The following is a description of a gene set: Human Gene Set: GSE26030_TH1_VS_TH17_RESTIMULATED_DAY15_POST_POLARIZATION_DN Serial comparison between Th1 and Th17 tumor-specific cells cultured in vitro and ex vivo after transferred into sublethaly irradiated B6.PL mice. Th17-derived cells acquire Th1-like properties in vivo but maintain a distinct molecular profile. studied in species Homo sapiens from publication Muranski P, Borman ZA, Kerkar SP, Klebanoff CA, Ji Y, Sanchez-Perez L, Sukumar M, Reger RN, Yu Z, Kern SJ, Roychoudhuri R, Ferreyra GA, Shen W, Durum SK, Feigenbaum L, Palmer DC, Antony PA, Chan CC, Laurence A, Danner RL, Gattinoni L, Restifo NP (PMID 22177921) Genes down-regulated in T helper cells 15 days post polarization and stimulated with anti-CD3 and anti-CD28: Th1 versus Th17., and this is the list of marker genes: ITGB1 (integrin subunit beta 1), DUSP7, RBM6, SAMD1, CD68, SSR4, MAP7D1, NDUFA7, TRNAU1AP, POLR2E, PIN4, SF3B3, GLIPR1, RNF130, DNAJC17, LYL1, TEX261, FCER1G, GNB2, PSMD9, COPE, SPI1, LIN37, NAA10, KCNE3, MTARC2, ATP6V1F, TCF25, SLC25A17, SPR, PDYN, SARS1, EIF4A3, STAT3, ACP6, VAMP8, RABAC1, CLK3, SRRM4, TUSC2, DCTN5, NKX2-3, CORO1A, ZNG1B, NSA2, NACC1, SIGMAR1, RPL19, SEC31A, PPP6R1, IDH2, TUBB4B, CCNL1, RNF5, PSMB7, NDUFA10, PMM1, COX8A (NCBI Gene Id 1351), USE1, ALAS2, STUB1, TSPAN33, PFDN5, FXYD5, FAU, CASP8, ACIN1, HROB, COPG1, VPS28, SLC11A1, AAMP, EDEM2, BTLA, ZMAT5, CTSA, EVI2A, BTF3, MRPL27, PCNA, GSTM5, SMAD2, RPL32, RNF167, ZFP3, IFI27L2 (interferon alpha inducible protein 27 like 2), ABRA, C5orf63, ACO2 (aconitase 2), RBM8A, RGS3, S100A6, EIF4G1, RRP7A, SUPT4H1, BRI3, PPIL2, EHD4, LAT2, NR1H3, STIM1, HIGD2A, VRK1, TFF3, PSME2, DGKA, CYTH2, SRI, FAM98C, RPL23A, DYNLT1, RPL41, MOB2, MRPL4, OTULINL, PTPN22, NUPR1, TMEM50A, SNRPG, PSME1, POLR3GL, RAB2A, RXRA, ATOX1, TMEM134, CD8B, PMS2, NDUFA11, HBB, SNRNP27, MYO1C, SIVA1, CDK5 (NCBI Gene Id 1020), CHD4, RPL24, SPG21, UQCRFS1, HMGB1, DCXR, TRIR, COX6B2, THYN1, PSMD8, PRDX5, CABIN1, PTPN6, MCMBP, BCL2A1, ISCU, PHAX, RPL11, PPP1R1A, STK32A, KCTD10, ADPRM, SELENOK, SEC61G, UBE2S, NCF2, CHMP2A, FIS1, NEAT1, TECR, JAK1, CD177, SLC35B2, ADCK2, ACAA2, RPL17, MED11, C9orf78, NDE1, DAPK3 (death associated protein kinase 3), CAPN2, UQCR10, NXT1, ACTL9, PTRHD1, NCBP2AS2, RPL38, HSBP1, RPS6KA1, GLS2, MRPL34, LDB1, OCIAD1, TNFRSF21, PTOV1, MBD3, GNGT2, ZNF511, CCDC180, QSOX1, IFNGR1, SDHD, DDX56, RPL34, AIP, MED8